Given this list of marker genes Pcna, Pold4, Ubb, Rfc4, Gtf2h2 (general transcription factor II H, polypeptide 2), Parp1, Pold1, Rfc2, Rbx1, Polk, Rpa3, Gtf2h1, Uba52, Ercc3, Ercc4 (excision repair cross-complementing rodent repair deficiency, complementation group 4), Cul4b, Rfc1, Rpa2, Ddb1, Ercc1, Ddb2, Gtf2h3 (general transcription factor IIH, polypeptide 3), Ubc, Gtf2h5, Pole4, Rfc5, Ercc5, Xpa, Rps27a, Ercc2, Chd1l, Pole3, Pole2, Pole, Pold2 (NCBI Gene Id 18972), Rpa1, Uba52rt, Gtf2h4, Pold3, Parp2, Rfc3, Cul4a, here is a description of the gene set: species: Mus musculus Mouse Gene Set: REACTOME_DUAL_INCISION_IN_GG_NER Dual Incision in GG-NER